The following is a description of a gene set: The cellular synthesis of microRNA (miRNA) transcripts. MicroRNA genes are synthesized as primary (pri) miRNA transcripts and subsequently processed to produce the ~22nt miRNAs that function in gene regulation. species: Homo sapiens Human Gene Set: GOBP_MIRNA_TRANSCRIPTION, and this is the list of marker genes: NCOR2, FOXO3, PAX6, NFATC4, IL6, FGF2, WT1, PRL, SMAD6, TGFB1, MYOCD (myocardin), PPARD, TP53, PPARA, GATA2, NFIB, FOSL1, HIF1A, NOTCH2, RELA, APLN, NR1H2, TGFB2, NOTCH3, GATA3, SMAD3, MYC, TEAD1, SMARCA4, NR3C1, GNL3, TNF, LILRB4, SMAD4, REST, DDX5, BMP2, POU5F1, SMAD1, PDGFB, VEGFA, SREBF2, SPI1, MRTFB, MRTFA, ETS1, NGFR, SOX9, FOS, BMPR1A, TWIST1, FOXA1, NFATC3, PPARG, MYB, ZNF512B, RARA, ATOH8, SRF, EGFR, AGT, TERT, POU2F1, YY1, NCOR1, SREBF1 (sterol regulatory element binding transcription factor 1), KLF4 (NCBI Gene Id 9314), EGR1, MYCN, AR, BMP4, JUN, APP, ESR1 (NCBI Gene Id 2099), IL10, STAT3